Given this list of marker genes Atp10a, Mapk7, Asxl2, Fam117a, Rdh1, Epgn (epithelial mitogen), Calml3, Grhl2, Scamp4, Timd5, Erbb4, Cstf2, Creld1, Nsd2, Phactr4, Tm9sf4, Dennd1b, Lyrm7, Tcf20, Strip2, Klc2, Becn2, Vapb, Pwwp3b, Mrtfb, Speer1e, Nr6a1, Bmp5, Snx12, Gli3, Psme4, Cntd1, Nexmif, Fktn, Ptbp3, Fndc5, Nipsnap2, Gigyf2, Appl2, Il23r, Pcdhb11, Slc6a2, Speer1m, Fndc3b, Rbm24, Hoxa5, Milr1, Ube2e3 (ubiquitin-conjugating enzyme E2E 3), Tmem121, Gxylt1, Ppp3r2, Arhgap26, Slc7a11, Ahcyl1, Necap1, Gabarapl1, Zfp148, Lpar2 (NCBI Gene Id 53978), Larp4, Als2, Tanc2, Uqcrfs1 (ubiquinol-cytochrome c reductase, Rieske iron-sulfur polypeptide 1), Sfxn4, Zbtb44, 4930524B15Rik, Lrrc30 (leucine rich repeat containing 30), Nop9, Asf1b, Igfbp5, Rdh9, Sh3glb1, Limk1, Epm2aip1, Lrrc34, Zfp987, Cachd1, Crem, Kcnd1, Speer1a, Neurl1a (neuralized E3 ubiquitin protein ligase 1A), Abl2, St8sia3, Myo6 (NCBI Gene Id 60360), Trpc5, Zfp583, Slc16a2, Atp6v1a, Unc5a, Isg20l2, Rhno1, Ghitm, Npr3, Asap3, Pof1b, Ttpa, Rdh19, Ptprb, Nup214, Nuak2, Pcx, Ppm1e, Rb1, Tbl1xr1, Col25a1, Exoc6b, Cwc25, Strn3, Dip2b, Nectin3 (nectin cell adhesion molecule 3), Stox2, Amer1, Phf6, Sstr1, Aff1, Slc38a2, A1cf, Zfp950, Nr2c1, Nvl, Snx27, Zfyve28, Gimap8, Cpd, Frmd5, Spink13, Cd226, Spg21, Kat6a, Kras, Orc3, Dclk1, Sh3pxd2a, Etv6, 1700019A02Rik, Sowahb, Eif2ak3, Brd2, Itm2b, Msi2, Mapkapk3, Add3, Deptor, Npy, Sobp, Akap13, Tspan13, Elmod1, Rnf146, Sytl5, St8sia4, Klhl20, Tmem41b, Phf11a, Vash1, Fyb1, Mogs (mannosyl-oligosaccharide glucosidase), Smndc1, here is a description of the gene set: from publication Chen Y, Wang X (PMID 31504780) Mouse Gene Set: MIR_143_3P Genes predicted to be targets of miRBase v22 microRNA mmu_miR_143_3p in miRDB v6.0 with MirTarget v4 prediction scores > 80 (high confidence targets). studied in species Mus musculus